Given this list of marker genes POU1F1, TBL1X, CPE, NKX2-5, MADD, IRS4, here is a description of the gene set: Human Gene Set: HP_DECREASED_CIRCULATING_FREE_T4_CONCENTRATION Decreased circulating free T4 concentration species: Homo sapiens A reduced concentration of free thyroxine (fT4) in the blood circulation.